The following is a description of a gene set: species: Mus musculus Any process that activates or increases the frequency, rate or extent of the chemical reactions and pathways resulting in the formation of hemoglobin, an oxygen carrying, conjugated protein containing four heme groups and globin. Mouse Gene Set: GOBP_POSITIVE_REGULATION_OF_HEMOGLOBIN_BIOSYNTHETIC_PROCESS, and this is the list of marker genes: Slc6a9, Klf4, Slc25a37, Abcb10, Ldb1